The following is a description of a gene set: The directed movement of D-glucose from outside of a cell, across the plasma membrane and into the cytosol. species: Homo sapiens Human Gene Set: GOBP_D_GLUCOSE_IMPORT_ACROSS_PLASMA_MEMBRANE, and this is the list of marker genes: SLC5A1, SLC5A2, SLC2A1, SLC2A10, SLC2A3